The following is a description of a gene set: The directed movement of the hexose monosaccharide glucose into a cell as a result of an insulin stimulus. Mouse Gene Set: GOBP_GLUCOSE_IMPORT_IN_RESPONSE_TO_INSULIN_STIMULUS studied in species Mus musculus, and this is the list of marker genes: Sgcb, Zdhhc7, Slc2a4, Trarg1, Slc27a4, Slc27a1